Given this list of marker genes Tnfsf14, Tmem182, Flt3l, Cd53, Myod1, Adgrb1, Ehd2, Ripor2, Gdf15, Cxcl9, Cflar, Capn2, Il4ra, Scgb3a1, Mapk14, Cxcl12, Nfatc2, Ccl8, Cxcl10, Il4, Ehd1, Flot1, Myog, Plekho1, Il36g, here is a description of the gene set: studied in species Mus musculus Any process that modulates the frequency, rate or extent of myoblast fusion. Mouse Gene Set: GOBP_REGULATION_OF_MYOBLAST_FUSION